Given this list of marker genes Pmm1, Lrrc2, Btg2, Tmem185a, Nectin4, Malat1, Ccng1, Zfp36l1, H2aj, Txnip, Vmp1, Mdm2, Trafd1, Cdkn1a, Tob1, Trp53inp1, Adgre1, Ei24, Cd53, Carhsp1, Pierce1, Ablim1, Lpin1, Lilrb4a (NCBI Gene Id 14728), here is a description of the gene set: studied in species Mus musculus Mouse Gene Set: BRACHAT_RESPONSE_TO_METHOTREXATE_UP DNA microarrays are powerful tools for the analysis of gene expression on a genomic scale. The importance of individual regulatory events for the process under study can however not be deduced unequivocally without additional experiments. We devised a strategy to identify central regulators of cancer drug responses by combining the results of microarray experiments with efficient methods for phenotypic testing of candidate genes. We exposed murine FL5.12 pro-B cells to cisplatin, camptothecin, methotrexate or paclitaxel, respectively and analysed the patterns of gene expression with cDNA microarrays. Drug-specific regulatory events as well as intersections between different apoptotic pathways, including previously studied responses to staurosporine and interleukin-3 (IL-3) deprivation, were identified. Genes shared by at least three pathways were chosen for further analysis. Ectopic expression of three such genes, TEAP, GP49B, and Lipin1 was found to have an anti-proliferative effect on pro-B cells. Interestingly, we identified hemoglobin alpha as a strong pro-apoptotic regulator. While hemoglobin-expressing cells were growing normally in the presence of IL-3, they displayed accelerated apoptosis with similar kinetics as Bax overexpressing cells upon IL-3 removal. The pro-apoptotic effect of hemoglobin was suppressed by Bcl-2 and was characterized by enhanced stimulation of caspase activity. Genes up-regulated in FL5.12 cells (pro-B lymphocyte) in response to methotrexate. from publication Brachat A, Pierrat B, Xynos A, Brecht K, Simonen M, Brüngger A, Heim J (PMID 12447701)